The following is a description of a gene set: from publication He P, Lim K, Sun D, Pett JP, Jeng Q, Polanski K, Dong Z, Bolt L, Richardson L, Mamanova L, Dabrowska M, Wilbrey-Clark A, Madissoon E, Tuong ZK, Dann E, Suo C, Goh I, Yoshida M, Nikolić MZ, Janes SM, He X, Barker RA, Teichmann SA, Marioni JC, Meyer KB, Rawlins EL (PMID 36493756) ILCP studied in species Homo sapiens Human Gene Set: HE_LIM_SUN_FETAL_LUNG_C4_ILCP_CELL, and this is the list of marker genes: CHKA, KRT86, MDFIC, PDZK1, LST1, MAN1A1, ELOVL6, FLNB, LPCAT4, KLF11, TCEAL4, IL23R, FAM174B, MAP3K7, CAMK1, SPECC1, KRT81, CTSH, PRAM1, TANC1, RUNX2, CCNG2 (NCBI Gene Id 901), SLC16A3, REEP3, TSPO, PPP1R9A, UBASH3B, HOOK1, TNFRSF18, NR4A3, CFH, ASB2 (NCBI Gene Id 51676), ELK3, HUNK, LTC4S, IL1R1, LIF (NCBI Gene Id 3976), SPINK2, ISOC1, SPATS2L (spermatogenesis associated serine rich 2 like), TTN, LZTFL1, CDK2AP1, SCRN1, HNRNPLL, EHBP1L1, GSN, TIMP1, PHYH, TEX30, NIBAN1, INPP1, TTC39C-AS1, MPRIP, TNFSF11, SSBP2, TNF, TOX2, CTSA, REPIN1, FUCA2, NET1, RASD1 (NCBI Gene Id 63428), NDRG1, MBOAT7, NCOA7, IFNGR2 (interferon gamma receptor 2), HPN, TMED8, FASN, CBFA2T2, SRGAP3, AHR (aryl hydrocarbon receptor), PRNP, FRY, SCN1B, PAPSS1, RGS2, LAPTM4B, SPRY1, NINJ1, DOK4 (docking protein 4), CXCR5, COL4A4, CEP170, AHI1, TNFRSF4 (NCBI Gene Id 7293), SLC40A1, BIRC3, IGFBP4, KCNQ5, AFF3, UNC93B1, PCDH9, PLD6, RIOX2, TIAM1, ELAPOR1 (NCBI Gene Id 57535), BCAS1, ATP8B4, RORC, ABHD15, MATN2, FSD1, LTA, SLCO2A1 (solute carrier organic anion transporter family member 2A1), CENPV, GDE1, ABCC1, ARHGAP6, AP1S1, IRF2BP2, ICAM1, CCDC50, PITPNM1, CCR6, GRAMD1B, PHTF1, JAG1, GGT1, PHF19, MARCKS (NCBI Gene Id 4082), ADAM12, DOK7, S100A13, RARG, NR1D2, KIT, CLEC11A, APP (amyloid beta precursor protein), SPART, LINC00299 (NCBI Gene Id 339789), PLPP1, TSPAN13, IL17RE, PECAM1, COL9A2, PEG10 (NCBI Gene Id 651242), NFATC1, FES, ATP1B1, GRN, GALE, MVB12B, GNPNAT1, COQ8A, TNFSF13B, GNA15, JMY, NR1D1, NOMO2, SH3TC1, POGLUT2, ZMIZ1, CST3, SLC4A10, CD81, DTD1, TRAPPC5, IGFBP7, ARL3, TSPAN4, CA2, EPS8L2, CLOCK, NRIP1, TTC7A (NCBI Gene Id 57217), GRAMD2B, IL4I1, HYI, PXMP2, ARHGAP10, LRRFIP2, ORAI3, CIDEB, DIAPH2, ZMIZ2, JAML, FURIN, ALDOC, PLCG2, RRBP1